The following is a description of a gene set: Reactome Pathway: SHC1 events in EGFR signaling studied in species Homo sapiens part of: Signaling by EGFR GRB2 can bind EGFR directly or through another SH2-containing protein, SHC1. This association leads to RAS activation., and this is the list of marker genes: HRAS, EGF, EPGN, GRB2, KRAS, TGFA, EGFR, AREG, SOS1, BTC, HBEGF, EREG, SHC1, NRAS